The following is a description of a gene set: Human Gene Set: GSE11973_MIR223_KOVS_WT_BONE_MARROW_NEUTROPHIL_UP This array analysis is to study the regulation of target messages’ expression in in vitro cultured murine neutrophils versus miR-223 null neutrophils. Culture media was SILAC-IMDM for MS analysis. species: Homo sapiens from publication Baek D, Villén J, Shin C, Camargo FD, Gygi SP, Bartel DP (PMID 18668037) Genes up-regulated in neutrophils from MIR223 bone marrow versus the wildtype cells., and this is the list of marker genes: JDP2, PCCB, HPCAL1, ACTG2, BMP7, ENO1, KLHDC2, MRPL3, SLC2A9, TLE3, COX6B1, ADSS2, RAD51, S100A6, OTULIN, SLC12A8, TCF19, DUSP1, TNFSF14, EHD1, ITGB3BP, RALGDS, TBCD, SLC9B2, RILPL2, SIN3B, EXOC6, PPCDC, TSPAN31, SOCS2, SELENOH, NAA38, CD22, RNF25, NUCB2 (nucleobindin 2), PNPO, CD74, CLEC4G, TSPAN5, APRT (adenine phosphoribosyltransferase), BIK, GNG10, CLCN5, VWA8 (von Willebrand factor A domain containing 8), AGFG1 (ArfGAP with FG repeats 1), SSR4, TCEA2, PANX1, SLC39A8, PSMD13, CCDC88C, G6PC3, AEBP2 (NCBI Gene Id 121536), CDH17, ERP44, MTAP, DRC1, CYP3A7, COMTD1, BLVRA, ELOVL3, RIPK3, EPN1, CXCL10, ARID5A, RAPGEF1, CPQ, ZNF622, MYO1G (NCBI Gene Id 64005), TPK1, SACM1L, GZMB, PLOD2, CNDP2, RTN4, TBC1D14, GCSH, CD9, SEC14L1, MRPL17, SNW1, FLNA, CKS2, VDAC2, DDRGK1, RIOX2, ITGA6, MRPL48, ACSL1, SEPTIN9, PNP, PECR, RBM3, IRAG2, ASRGL1, VTI1A, NUDT14, LRBA, UFC1, LRATD1, PPIC, BAIAP3 (NCBI Gene Id 8938), PRKCB, S100A4, PHGDH, SLC25A4, VDR, GSTT2, HLA-DOA (NCBI Gene Id 51034), RPIA, SCG5, SLC25A24, RNF32, DENND2D (NCBI Gene Id 79961), EMC2, ATP9A, SERPINC1, UBE2A, RPA1, CEMIP2, TP53I13, PPIB, CYB5R3, XRCC5, GOLIM4, EIF4B, RAP1A, ASS1, MBD2, PLAC8, PPP2R1B, TOP2A, NDUFC1, PSMD2, PRSS16, MBIP, CS, THY1, EZH2, CDC6, PSD3, USE1, RNF43, CXCR5, MAD2L1, FBXW7, MED16, SLC66A3, PGLS, KIF1B, POLR1E, RAB37, AHI1, HTATIP2, URM1, CD5L, NAB1, WASHC3, CDK5R1, SLC39A11, MFSD1, RECK, TNFSF11, PRMT1, LYL1, USP36, MPND, LTA, ALDOC, DUSP6, CRYBG3, FABP5, CACNG6, CD52, CD300A, TFRC, C9orf85, WLS, RNF19B, E2F8, VWA5A (NCBI Gene Id 4013), CD38, DNASE1L1, HPGD, DPP4, ETF1, ZCCHC18, TIAM1, TNFRSF4, TNFSF8, IGF2-AS, KIFC2, REXO2, PRDX4, BMP2K, CREB3, FYN, NAA10, NUBP1, EXTL1